Given this list of marker genes C4orf54, IBTK (NCBI Gene Id 25998), NOTCH4, NCF4, CXXC5, DOCK6, SHCBP1, MAPK1, RBPJ, RAC1, GTF2I, MAPK3, SP1, CYBA, NCF1, ARHGAP31, SBDS, CYBC1, CDC42, DGUOK, EIF6, NFKB1, TLR9, EOGT, ESR1, NOX3, CHCHD2, BEND6, KCNN3, NOTCH1, BTK, COX4I2, EFL1, TLR8, NCF2, DLL4, CYBB, here is a description of the gene set: studied in species Homo sapiens Human Gene Set: WP_GENETIC_CAUSES_OF_PORTOSINUSOIDAL_VASCULAR_DISEASE Genetic causes of porto-sinusoidal vascular disease